Given this list of marker genes Ska2, Tmem198b, H2ac7, Hnrnpdl, Ddx42, Ube2f, F730016J06Rik, Poldip3, Col2a1, Disp3, Clptm1l, Phtf2, Mbtd1, Acvr1, Prpf18, 2900009J06Rik, Pdgfa, Abca2, Mdga1, Gm28513, Mir124-2hg, Dhx16, Yars2, Med23, Psd3, Cntn4, Gm5113, Zbtb44, Wbp2, Sfrp1, Msh2, Wiz, Acbd4, Lemd1, Ppp1r37, Riok3, Abca4, Agbl4, Sra1, Zcchc14, Npvf, Snora17, Gm16170, Rgs8, Atp5po (NCBI Gene Id 28080), Zkscan5, Gm13889 (predicted gene 13889), Immt, Gm2093, Arhgap32, Fxr2, Ttll11 (NCBI Gene Id 99233), Snord42b, Fgf3, Spag9, Myh3, Il4ra, Rad9b, C2cd5 (NCBI Gene Id 77314), Mpped2, Tacr1, Rasgef1b, Ifnar2 (interferon (alpha and beta) receptor 2), Tmem167, Lxn, Ndufaf5, Slc39a3, Inka2, Pcsk5, Mpnd, Mir8109, Ttc21b, Dctn5, Gm5614, Nr2e1, Brd8, Asb7, Rrm1, Pyroxd1, Gbf1, Pdss2, Bcl11b, 9330111N05Rik, Zbtb22, Glce, Kcnip3, Sox1ot, Igf2bp3, Elof1, Zfp354b, Zbtb40, Gtf2b, Lsm6, Tyms, 5930403N24Rik (NCBI Gene Id 320504), Pkm, Mrps27, Trp53bp1, Asb6, 5031434O11Rik, Kdm8, Mtcl3, A930019D19Rik, Mir8103, Ncoa2, Dlx1, Tsfm, Ecd (NCBI Gene Id 70601), Ift22, Mir6352, Zhx1, Kif5c, Katnip, Sema5b, Tnpo2, Nt5c3, Rpl27, Il18rap, Tnrc18, Gcnt2, Surf6, Pkig, Arid3b, Cox7a2l, Emc1, Neat1, Pcbp2 (poly(rC) binding protein 2), Oip5, Elavl4, Smad7, Gm5083, Mreg, Trim8, Mast1, Ddx56, Grn, Maf1, Wdr31, Gm12830, Dmxl1, Khk (NCBI Gene Id 16548), Zfp68, Gmfb, Atp5mg, Gm3235, Plxnb1 (NCBI Gene Id 70220), Osbpl3, Rhot1, Kmt2c, Coq6, Gm9929, Tmem250, Klf7, Pex13, Calm1, Rny3, Wars1, Ppp6r3, AI849053, Sox4, Gm10655, Ephb3, Tbl1xr1, Stpg1, Memo1, Wrap53, Trmt1, Polr3g, Acsl3, Racgap1, Mdga2, H2bc7, Ascl1, Cpeb2, Islr2, Ccnd2, Gli2, Cpe, Hspb3, Tle4, Sdad1, Sptan1, Gm10484, A730036I17Rik, Il17d, Neurl4, Odf2l, A130050O07Rik, Tyro3, 1700010H22Rik, Trappc8, Glul, Tmem150cos, Krtap3-3, Xpnpep3, Tcp1, Hnrnph1, Wdr18, Timm21, Cct7, Mtdh (metadherin), Snhg7os, Rraga, Slc35e1 (NCBI Gene Id 270066), Per1, Otx2, Arid1a, Mad2l1, E130006D01Rik, Gprasp1, Slc35a4, Celf2, Ppp1r9b, Hnrnpu, I830134H01Rik, 4933427D14Rik, Uncx, Rad51b, Ntrk2, Gm42918, Marchf3, Septin9 (NCBI Gene Id 53860), Fbln1, Bmal1, 4930577N17Rik, Copz1, Plcb1, Scrt2, Gm10610, Tlx3 (NCBI Gene Id 27140), Atxn7l1 (NCBI Gene Id 72174), Ints14, Ngef, Hint2, F830212C03Rik, Rabgap1, Crebbp, Vps11, Cdiptos (CDIP transferase, opposite strand), Dhx35, Mnt, Syn3, Nipal3, Srrm4 (serine/arginine repetitive matrix 4), Zfp536, Reep2, 2410004B18Rik, Nelfcd, Nuf2, Mlxipl, Pxylp1, Gpn3, Cln3 (CLN3 lysosomal/endosomal transmembrane protein, battenin), Mrps17, Gm2566, Snx18, Slc39a6, Cops2, Tmem248, Mir1907 (microRNA 1907), Zswim6, Lrriq1, Clcn3, Mlc1, 3110056K07Rik, Cox6c, Dnaaf5, Ubfd1, Ybx3, Cdh2 (cadherin 2), Plpp7, Espl1, Ermn, Sall3, Rab2b, Srm, Gm20646, Nudt9, Sav1, Obi1, Pde1a, Gtf2f2, A330102I10Rik, Sox11, Gm7041, Abi2, Prkrip1, Zfp219, Nfia (NCBI Gene Id 68838), Mmp14, Camta1, 4930404H24Rik, Gucy1b2, Cdk14 (cyclin dependent kinase 14), Oga, Rad21, Tsc22d1, Maml3, Camk1g, Rpl32, Pou2f3, Ensa, Pip5k1a, Gm15322, Mm2pr, Yipf6, Elmo1, 4930445N08Rik, Napg, B230216N24Rik, Pank1, Hspa9, Golga7 (golgin A7), Aaas, Rab3b, 1700039I01Rik, Atp5mc3, Rad54l, Pantr1, Mycn, Eif3f, Gpcpd1, A330074K22Rik, Dusp6, Dido1, Dll1, Gm43522, Sigmar1, Cyp4b1-ps1, Mcts1, Nuak2, Lypd1, Pcbp1, Dnajc24, 5730480H06Rik, Rbm25, Pofut1, Dedd, Cenpu, Junos, Galt, Ube2j2, Sema6d, Mir125b-1, Ank2, Leo1, Myt1l, Plagl2, Hif1an, Ptpn9, Prr11, Gm36667, Tubd1, Uba1, Ambn, Gid8, Rab13, Tsc22d4, Esrrg, H4c9, Trerf1, Trap1, Ccdc88c, Adgrv1, Commd1, Cep55, Gm10248, Zbtb18 (NCBI Gene Id 30928, zinc finger and BTB domain containing 18), Lhx9, Ssbp3, Msx2, Tmem242, Dlx1as (distal-less homeobox 1, antisense), Dnajb4, Setdb1, Adarb2, Mir7-2, Gm25541, Phc2, Lrpap1, Cct4, Plekha6, Mta2, Tmed2, Igfbp4, Xrcc4, Ivd, F630040K05Rik, Rere, C130026L21Rik, Gm14089, Dlx6, Wdr35, Atp6v0d1, Nsg2, Sharpin (SHANK-associated RH domain interacting protein), A230028O05Rik, Smcr8, Fra10ac1, Mn1, Mir124a-2 (microRNA 124a-2), Ctnnb1, Tfap2c, Slc35b1, A830011K09Rik (NCBI Gene Id 319702), Gm3764, Fam181b, Mir1936, Elmod3, Crtac1, Fzd1, Snord68, Bcas2, Xxylt1, Cnot1, Spr-ps1, Gm13783, Npas3, Helz, Vps36, Coa7, Gm5254, Psmf1, Fndc3a, Pold3, Syt16, Pcdh9 (protocadherin 9), Fam135a, Nfatc2ip, Psmd9, Bloc1s3, Filip1, Nicn1, Nkiras2, Sh3glb1, Sde2, Nmbr, Atp2b2, H2ac10, Ankrd10, Flywch1, Ptdss1, Vrk3, Tdrkh, Secisbp2l, Zfyve26, Crbn, Rptor, Psmc1, Tomm40l, Adnp, Fancc, Zmynd12, Mir7687, N4bp2, Dnajc1, Phactr3, Ccnk, Lrig1, Ndufa5, Rhcg, Kansl1, Farsb, Mvk, Gm16023, Ube2i, Paupar, Arel1, Zpr1, Mblac2, Thtpa, 4930521E06Rik, Asnsd1, Reno1, Scn2a, Enoph1, Alg5, 4930445N18Rik, Zmiz1, Uqcrb, Ruvbl2, Chn1, Stk33, 3000002C10Rik, Kctd15, Tmem163, Cbln2, AF357399, G630016G05Rik, Mcc, Insm1, Tmem168, Cfap61 (NCBI Gene Id 99460), Crem (NCBI Gene Id 12916), Wt1os, Cecr2, Mrpl18, Nckap5, Tgds, Tmtc3, St13, Gm13415, Cops6, Men1, 1700039M10Rik, Syncrip, Klhdc10, Tlr1, Tubb5, Zbtb6, Pisd, Lin28b, Ankle2, Neurog1, Mir7238, Sbds, Apba2, Map2k6, Vps18, Zfp408, Hdac9, Plekhg2, Maz, Poc5, Usp9x, Chmp5, Selenbp1, Atf7ip, Arl1, Tle3, Gmpr2 (NCBI Gene Id 70653), Gtf3c4, Polr3f, Tmx2, Plpp3 (phospholipid phosphatase 3), Cep290, C820005J03Rik, Ube2ql1, Lrrc61, Pradc1, Prmt3, Crcp, Zfhx4, Mrto4, Rbfox3, Gipc1, Frs3, Mfap1b, Pus10, Pkdcc (NCBI Gene Id 13934), Cdk11b, Pbx2, Vamp1, Rnf135, Trub1, Ankrd44, Ftx, Cdc25a, Sec22b, 0610040B10Rik, Upp2, Arhgap1, Pou3f2, Necap2, A730056A06Rik, 3300002A11Rik, Gm13268, Ttc41, Gm16160, Phox2b, Ubr4, Gm11520, Mir423, Mir8098, Hes5, Emx2, Prkar1b, Akt2, Gsx1, Nr6a1, Tmem65, Eif4a1, Dffa, Kif20a, Mterf3, Dzank1, Nol4, 1700023G09Rik, Slc4a1ap, Siah3, Rbm14, Slc26a7, Fam149b, Atp5mc2, Ints6l, Chodl, Nme1, Hdac5, Cdc42bpb, Mir9768, Nhlrc3, Gm38250, Myc, Katnal1, A830082K12Rik, Rtcb, Prima1, Glrx5, Uspl1, Gnb1l, Bend4, Zfp207, En2, Tor2a, Dusp23, Pnpt1, 1810007C17Rik, Rhbdd3, Dnajc11, Vps45, Mapkbp1, Vldlr, Ttc19, Gm11587, 2810408A11Rik, 4930503O07Rik, Chaserr, A730013G03Rik, Vps29, 1700007L15Rik, Ambra1, Frem1, Gatc, St18, Crls1, Nat10, Arhgap11a, Rfx4, Rbm8a, Gdpd5, E2f4, Ppp1r8, Gm12925, Usp4, Pih1d1, 2700033N17Rik, Cdkn2aipnl, Top3a, Mtres1, Neu1, Vgll4, A730061H03Rik, Urod, Nf2, Taok3, Snord43, Elp3, Tspyl2, Gclm, Fezf1, Setd3, Tspan18, Hpgds, Epc2, Plxna2, Myl6, Hbp1 (high mobility group box transcription factor 1), Gys1, Apba1, Arl5b, Cacfd1, Bcas3, 5930430L01Rik, Utp3, Nosip, Il4i1, Ccnt2, Gabpb2, Map2k7, Lman1, Nme5, Mtmr9, Fbxo11, Smarca2, Cep120, Gins4, Nsfl1c, Rbm42, Anapc15, Ass1, Pfdn4, Pdzrn3, Utp18, Lins1, Scfd1, Pigm, Rnasel, Gm23856, Tgfbr3, Tcf4, Psmd1, Flad1, Tamm41, Gm9530, 1700056E22Rik, Rps6ka2, Ndufa13, Ssbp2, Angel2, Gtf2ird1, Lix1l, 2610005L07Rik, Meg3, Mfng, Ccdc47 (coiled-coil domain containing 47), Sphk2, Gm20544, Exosc8, Ostm1, Rufy3, Nifk, Ccdc124, Tshz1, Ccdc150, Myl4, Slc33a1, Kcnip1, Coro1c, Pgp, Gm13853 (NCBI Gene Id 102634837), Mcrs1, Rbpj (recombination signal binding protein for immunoglobulin kappa J region), Mpp2, Gm26608, 1700040D17Rik, Mir760, Palld, Blvra, Cyp2j9, Fdft1, Pten, 5730522E02Rik, Mob4, Hadhb, Dgki, Adam11, Nectin3 (nectin cell adhesion molecule 3), Hes6, Pum2, Adprs, Chd2, Fkbp5 (FK506 binding protein 5), 1700028E10Rik, Mir9-3hg, Zfp524, Ankrd37, Ighmbp2, H2ax, Abhd13, Ablim1, Katnal2, Trip12, Pik3r4 (NCBI Gene Id 97556), Lsm11, Rps18-ps4, Dennd6b, Supt4a, Sp9, Mamdc4, Dpp8, Snx17, Ago2, Utp20, E230029C05Rik, Jag1 (NCBI Gene Id 170642), Dnaaf9, Mycbp2, Rps5, Acp2, Msl2, Snord118, Tnks1bp1, Bambi, Dennd10, Csmd3, Slc4a2, Sp5, Psmd3, Krt73, Ufm1, Zfhx2, Nhsl1, Rnps1, Mttp, Lmcd1, 6820431F20Rik, Fam171a2, Hmgb1-ps1, Mir124a-1, Osbp, Gins1, Tpgs1, Zfp608, Gm25296, Irs2, Mir1897 (NCBI Gene Id 100316679), Wdfy2 (WD repeat and FYVE domain containing 2), Ppp1r7, Armcx5, Tubb4b, Tsn, Vps33a, Gm24288, 4933400C23Rik, Zeb2os, Rangap1, Foxn3, Tmem104, Ntm, Sox1 (NCBI Gene Id 20664), Otx2os1, Anapc5, Prps1, Pfn2, Glud1, Mir344f, Nudt5, Celf1, Ewsr1, Vta1, Pask, Ubp1, H3c7, Hectd3, Gm13133, Paxbp1, 6330549D23Rik, Gm13610, Sorbs2, Abhd10, Mpp3, Fgf7, Cstf2t, Hadha, F730043M19Rik, D330041H03Rik, Hdgf, Ncbp3, Mir92b, Fzd2, Nsrp1, Myo10, Mrpl21, Ppme1, Rimoc1, Lrp10, Zfpl1, Sap30bp, Kntc1, Mxi1, Pou3f4, Gm11690, Lig4, Zfand6, Frzb, Gm16223, Gm14207, Prickle2, Tomm6, Vps13d, Magi2, Casz1, Cul2, Lmnb1, Mir344-2, Smarcal1, Rai1, Dolpp1, Polr2a, 3110039M20Rik, Itgbl1, Ftl1, Zfp46, Eef1akmt1, 1600029O15Rik, Tubb3, Gpm6b (glycoprotein m6b), Senp1, Hmgn2, Emx2os, Mesd, Sucla2, C030034L19Rik, Por, Shb, Six2, Lhx6, Dst, Nipsnap2, Gm25261, 2610307P16Rik, Fiz1, Eapp, Rnf216, C2cd3, Nme6, Zfp563, Cdk5, Mkrn3, Gm15527, Fam13c (NCBI Gene Id 77489), H3c6, Mtmr6, Gm6615, Usp39, Mllt3, Prdm4, Dcp1a, Anks1b, Nudcd2, Tmem167b, 1700016A09Rik, Snhg17, Fam193b, Kifap3, Tchp, Mia2, Dusp7, Med17, Rps6kb1, 1810024B03Rik, Gm22827, Mgat4c, Pou2f1, Retsat, Brsk1, Ndufs2, Pax6, Ppa1, Wwc2, Mlip, Hexim2, Tcaf2, Ipo8, Gata4, Usp1, Gm20515, Extl3, Chek2 (NCBI Gene Id 50883), Ddx24, B530045E10Rik, Wasf2, Tcf12, Mir9-2hg, Dlx5, Epc1, Asf1a, Dynll2, Dlg4, Plk2, Gm10039, Sash1, Dnajb11, Fktn, Slc16a13, Acin1, Nfix, Rpl23a, Taf5, Auts2, Sart1, Dennd4b, Gm8501, Exd2, Tox4, Abcb9, Coasy, Tram1, Dhrs13, Mfap4, Med29, Mmab, Rps7, Nr1h3, Ciao3, Lingo1, Jmjd1c, Rcor1, Vapb, Ptpn21 (protein tyrosine phosphatase, non-receptor type 21), Cdca8, Tyw1, Flrt3, Zmat4 (zinc finger, matrin type 4), Elf3 (NCBI Gene Id 13710), Bcl7c, Sox2ot (SOX2 overlapping transcript (non-protein coding)), Tti2, Znhit3, Gm17494, Dgat1, Trpm1, Abca8a, Defb2, Gm26604, Rps11-ps3, Bahcc1, A930005H10Rik, Adam17, Stk40, Gnb2, Robo3, Cox18, Nol4l, Arl2bp, 9630028B13Rik, Coro2b, 4933402N03Rik (NCBI Gene Id 67431), Frg1, Inafm2, Gosr2, Maea, Cks2, Adgrl1, Asic5 (acid-sensing ion channel family member 5), Bmpr1b, Eola1, Tmcc1, Nedd8, Alyref2, Tbccd1, n-R5s28, Sema6a, Nup214, Mir153, A230077H06Rik, Nfib (nuclear factor I/B), Acp6, Proser1, Lpin1, Tmem138, Gorasp2, Mat2a, Pik3r3, Polr3k, Zeb2, Pagr1a, Chmp7, Ttc5, Ogt, BB218582, Zfp473, Gm26812, Gm12676, Tmem39b, Kpna6, Dnajc19, Idh1, Naxd, Cstad, Macrod2, Grin2d, Ppox, Pex3, Prpf38a, Gm22379, Elavl2, Map2, Lars1, Pomt1, Chd3, Alkbh8, Hscb, Tbp, Triap1, Dnah11, Axin2, Dct, Plcxd3, Atf6, Or1e27-ps1, Ldlrad3, Apbb2 (amyloid beta precursor protein binding family B member 2), Foxp2, Ice1, Tlr6, Nrf1, Yjefn3, Med25, Atp5mf, Bcl9, Kat6b, Gramd1b, B230112J18Rik, Ypel1, Lmo4, Fgfr2, Cc2d2a, Mcub, Klhl5, Foxg1, Pak5, Dnah5, Gm33051, Nacc2, Ist1, Gm13031, Wdr25, Commd4, Trp53rka, Nrxn3 (NCBI Gene Id 77507), Dhx33, Dcaf17, Mir496b, Trps1, Gm10441, Znhit1, Mapk11, 0610031O16Rik, Rnf170, Lmo3, Mir8120, Asl, Cs, Gm2109, Aicda, Psmb6, Dysf, Pdxdc1, Srrm3, Rbms3, Zfp148, Mir124a-1hg, Lix1 (limb and CNS expressed 1), Sox2, Aadat, Ralgapa2, Tcte2, 1700023H06Rik, Zfp281, Mir6540, Get1, Tomm40, Slc25a17, Ctdsp2, Pcnx3, Tmem161a, Ap3m2, Rnu12, Gm21992, H2bc18, Hikeshi, Zfp704, 4632415L05Rik, Vmn1r4, Hnf1b, 9330198N18Rik (RIKEN cDNA 9330198N18 gene), Wdr76, Aph1a, Limch1, Uqcc4, Coq8a, Gm17435, Stag1, Gins3, Dnajc16, Tmem60, Tmem69, Tet1, Rpia, Fbxo36, Zfp428, Mir6380, Esf1, Rps16, Zfp51, Plod3, Nusap1, Dhrs7b, Nemf, Rpl36, Akap6, Snord13, Ube4a, Khdrbs1, Magi1, Ptch1, Fndc4, Trpc4ap, Mapkapk2, Hmmr, 1700042O10Rik, Lnpk, Unc13b, Dcdc5, Ddit3, Rian, Ibsp, Blmh, Ube2e1, Fem1c, Mir5129, Clcn5, Ears2, Nufip2, Marcks, Gm12508, Tysnd1, Svopl, Trim2, Clpx, Grik4, Sel1l, Arhgef26, 1700041G16Rik, Slc35f1, Borcs6, Gm12063, Pitpnm3, Zc3h4, Pasd1, Rack1, Tubb2b, Chchd3, Rxra, Prp2rt, Rsrc2, Cep170, Dcaf8, Ankrd6, Gale, Hnrnpl, Rpl38, Ppcs, Zdhhc4, Gm17750, Hddc3, Dhx29, Wdr43, Prrx1, Dcaf11, Wdpcp, Mipep, Mipepos, Psmd12, Arrdc3, Cdca5 (cell division cycle associated 5), Wdr95, Fam167a, Cwc22, Pim1, Otud6b, Nav3, Fcf1, Dipk1a, AI480526, Med6, Msrb3, Cherp, G2e3, H4c16, Tctn1, Pou3f3, Ripor2, Fitm2, Rpl3, Ptcd2, 5830416I19Rik, Timm10, BC002059, 6330403K07Rik, Lrp8os2, 2610037D02Rik, Zbtb20, Ndufa9, 1600020E01Rik, Gm27011, Gm9989, Zfp521, Palb2, Slc6a2, Mir3078, Elp2, Kat7, Bsdc1, Negr1, Gm2287, Tmem121b, Chordc1, Mus81, Ncoa4-ps, Kmt2b, Bahd1, Cadps2, Usp49, Ankrd40, Phpt1, Cux2, Zfp213, Sulf2, Gm15831, Fem1a, Otub1, Opa3, Tmcc3, Mir8114, Mcf2l, Parvaos, Gm11266, Zfp146, Kdm6a (NCBI Gene Id 22289), Nucks1, Tal1, Dhx8, Erlin2, Cntnap2, Mob3b, Fam32a, Jun, Gm11655 (predicted gene 11655), Zfp703, Prrg2, Polr2e, Kxd1, Rfc2, Bmf, Adam22 (a disintegrin and metallopeptidase domain 22), Chchd5, Hdac2, Recql5, Polr3gl, 4930430O22Rik, Epha5, Eed, Mvb12b, Snrnp200, Kmt2a, Gadd45g, Rhbdl2, Poc1a, Zc3h6, Fbxw7, Paip2b, 2310001K24Rik, Slc25a23, Pop5, Gm4925, Hgh1, Fam161b, Satb1, Mir6359, Gm13569, Rapgef1, Cdk2ap1, Pank4, Ubald2, Nsun5, Tapbp, Acbd6, Rnd3 (NCBI Gene Id 99050), Fam216a, Arrdc4, Med4, Prr13, Trp53, Mtln, Cenps, Hat1, Zfp91, Cfap43, Gosr1, Mrps21, Yipf2 (Yip1 domain family, member 2), Fryl, Ms4a20, Gpm6a, Mir99ahg, Ap4e1, Alkbh5, Scarna2, Lingo2, Lrpprc, Mir100hg, Tub, Entpd1, Eif2b4, Mtx1, Ptprr, Zfp609, Pafah2, 2810405F15Rik, Bod1l, Krit1, Rpl31-ps20, Rmi2, Gm10544, Paf1, Rbfox2, Ikzf2, Incenp, Dhx34, Armc1, Golga1, Sdk1 (sidekick cell adhesion molecule 1), Adam23, Gm17112, Arpc3, Atp2c1, Zfp458, Cdc123, Dlx2, Fgd4 (NCBI Gene Id 320417), Arid1b, Spock1, Polr3h, Nat9, Lpcat4, Ddx41, Utp14b, Sntb2, Pdcd2l, Asb15, Mir1251, Gpr180, Ncam1, Slc25a51, Neurog2, Hsp90b1, Nono, C920021L13Rik, Kifc1, Ddx47, Olfml3, Rpl18, Fhl1, Arhgef10l, Orc1, Nr2f1, Tent2, Cdipt, Cnot11, Zfp106, Mir1948, Dlgap2, Wdr41, Ints4, Schip1, Mtf2, Gm42632, Phactr1, Ido1, Jarid2, Trappc3l, Lhx2, Dlx6os1, Vcp, Ddx46, Pou2af2, Gm15401, Erc1, Clptm1, Pelp1, Med19, 1600014C23Rik, Gm27239, Ccdc177, Snapin, Usp30, Gm13421, Vax1, Eef1a1, Zfp41, Chek1, Bicdl1, 9430069I07Rik, Banp, BC006965, Rsbn1, Polr3a, Ccdc174, Pde4d, Edem1, Arsk, Aatk, Ddx31, Ubac1, Washc2, Ephb1, Zmynd8, Tbc1d10b, Gclc, Txn1, Mfap1a, Golga4, Foxp1, Frmd4b, Rsrc1, Mir669n, Ebf1, Lyrm7, Gm13203, Tmem67, Gm24204, Ehbp1, Airim, Ankrd22, Mapkapk5, Rragc, Gm13586, Ramacl, A330093E20Rik, Six3, 1110002J07Rik (NCBI Gene Id 68488), Nrxn2, Skic3, Sorl1, Apmap, Cxxc4, Atf5, Helt, Meis2, Ypel5, Stip1, Dixdc1, Gss, Ski, Hmgn1, Mir6403, Antkmt, Adgrl2, Dock7, Opa1, Zbtb26, Ndufaf4, Igfbp5, D030056L22Rik, Aldh16a1, Nrep, Nap1l1, Gm16133, Dpys, Commd5, Snrpc, Cilk1, Cacna2d2 (calcium channel, voltage-dependent, alpha 2/delta subunit 2), Arid4a, Clasp1, 2900052L18Rik, Bcar3, H2ac8, Xrcc2, Supt7l, Cdc27, Rmnd5a, Ppt1, Gm5544, Serpinb2, Myt1, Atl2, Hnrnpc (heterogeneous nuclear ribonucleoprotein C), Irf1, Agrn, Dph5, Tbcd, Gm10748, Mir5133, Dlk1, Sh3gl1, 1700073E17Rik, Nrxn1, Tex2, Rnf26, Mid1ip1, Top2a, Dnttip2, Smim11, Map3k11, 3110082J24Rik, H2bc8, Scml4, Gse1, Cyb561a3, Gm11772, Rnu11, Gatad2b, Rpl13, Gas1, Mbd6, H4c14, Fnbp4, Itgav, Clip2, Pum3, Ints10, Snora7a, Gm29455, Bag1, Mtrex, Galk2, Dcx, Olig2, here is a description of the gene set: from publication Yevshin I, Sharipov R, Kolmykov S, Kondrakhin Y, Kolpakov F (PMID 30445619) Mouse Gene Set: DLX2_TARGET_GENES Genes containing one or more binding sites for (Dlx2) in their promoter regions (TSS -1000,+100 bp) as identified by GTRD version 20.06 ChIP-seq harmonization. species: Mus musculus